Given this list of marker genes Fdxr, Kras, Aurka, Atad5, Ranbp2, S100a4, Cbx7, Ndrg2, Bap1, Dkc1, Btg3, Becn1, Mlh1, Nrbp1, Il12rb2, Cdkn2a, Ogg1, Plk1, Cdkn1a, here is a description of the gene set: studied in species Mus musculus Mouse Gene Set: MP_INCREASED_LUNG_CARCINOMA_INCIDENCE from publication Motenko H, Neuhauser SB, O'Keefe M, Richardson JE (PMID 26092688) Mouse genes annotated to increased lung carcinoma incidence (MP:0008714) retrieved from the Mouse Genome Informatics database via MouseMine